Given this list of marker genes Hnrnpa2b1, Sfswap, Srsf7, Tmbim6, Sap18 (Sin3-associated polypeptide 18), Akt2, Rbmxl1, Pcbp4, U2af2, Rnps1, Rps13, C1qbp, Sap18b, Srsf6, Srsf10, Rbm20, Celf4, Srsf9, Hnrnpk, Ptbp2, Npm1, Akr1c6, Srsf4, Acin1, Rps26, Rbm10, Dyrk1a, Ptbp1, Rbm42, Ptbp3, here is a description of the gene set: Mouse Gene Set: GOBP_NEGATIVE_REGULATION_OF_RNA_SPLICING species: Mus musculus Any process that stops, prevents, or reduces the frequency, rate or extent of RNA splicing.